The following is a description of a gene set: Human Gene Set: GOCC_CELL_SUBSTRATE_JUNCTION A cell junction that forms a connection between a cell and the extracellular matrix. species: Homo sapiens, and this is the list of marker genes: TRIM15, RPS19, ITGB1, RAB21, DMD, NHERF2, PPP1CB (NCBI Gene Id 5500), EFS, THSD1, PVR, IQGAP1, ITGB4, FLT1, RHOG, JAK1, CSPG4, NME2, PDLIM7, RPL7, HSPA8, TPM4, HACD3, CNN1, VIM, SENP1, EPHA2, KIF23, PPIA, LPXN, DND1, CAPN5, LASP1, SRCIN1, NPM1, FBLN7, TM4SF20, ITGA2, LRP1, ASAP3, IGF2R, DCTN4, RPS5, MDC1, AFAP1, RDX (radixin), PRUNE1 (prune exopolyphosphatase 1), PIP5K1C, COL17A1, TES, IRF2, PALLD, ATP6V0C, FBLIM1, YWHAG, DST, PTPN12 (protein tyrosine phosphatase non-receptor type 12), FERMT3, FHL2, HMCN1, TLN1, HMGA1, ADAM9, SVIL, UBOX5, PPFIA1 (NCBI Gene Id 8500), ACTB, RPL37A, RPL27, PRAG1, TNC, CDH13, CPNE3, CORO2B, GRB7, CSRP1, PTPRC, TLN2, FERMT1, GNB2, ARHGAP24, LIMD1, SLC4A2, RPL13A, PPFIBP1, MCAM, CNN2, TLE2, MSN, LIMS2, GAK, ITGB1BP1, NRAP, RPL7A, NPHS1, PEAK1, RSU1 (NCBI Gene Id 6251), RRAS, AIF1L, CORO1B, ARPC3, PAK1, SORBS2, G3BP1, ACTC1, RPL30, TWF1, PLAU, CD81, DAG1, RPL3 (ribosomal protein L3), CD44, ADGRB1, PTK2, GJA1, ITGA6, CAT, KRAS, PFN1, PCBP2, YES1, NECTIN2, GSN, TADA1, RPS10, ADAM10 (NCBI Gene Id 102), ACTG1, SMPX, IL1RL1, EZR, ITGB3, ACTN4, FHL1, S100A7, FLOT1 (flotillin 1), SLC6A4, ARPC5L, RPL23, CD46, MARCKS, FLNA, DLC1, RPS17, NUMB, PPP1R12A, RPS8, HSP90B1, HSPA1B, SPRY4, SDC4, PLEC, ENG, ARF1, FLNB, BSG, RPS16, PLAUR, CYBA, B2M, ITGA4, LMO7, RPL6 (NCBI Gene Id 6128), APBB1IP, ARHGEF2, PXN, AHNAK, PROCR, PDIA3, NHS, GNA12, CAP1, PGM5, VASP, CLASP1, ITGB8, GFRAL, AMBRA1, SCARF2, CLTC, FES, ITGB2, ADAM17 (NCBI Gene Id 6868), RRAS2, RHOU, PAK2, ARPC2, CNN3, ARPC5, LIMS1, LAYN, NCSTN, ARHGAP22, PI4KA, PDGFRB (platelet derived growth factor receptor beta), MPRIP, ZYX, HSPB1, ACTR2, SRC, PPIB, FLNC, PDLIM1, AKAP12, ITGB7, CASS4, DDR2, TSPAN9, RPL5, CDH2, ABCB4, MME, ITGA2B, ADD1, CAPN1, ADGRE5, DAB2, SYNE2, MAP2K1, MPZL1, LCP1, CTNNB1, JAK2, PARVB, CDC42, SH3KBP1, SORBS3, YWHAB, ITGB6, RAC2, SYNPO2, GIT1, RPS18, MRC2, FHL3, NEDD9, TEK, ACTR3, CHP1, TSPAN4, RPL18, MAPK1, FLII, CORO1C, ATP6V0A2, PTPRA, FGFR3, PARVG (parvin gamma), FLRT2, RPL12, EPB41L2, USP33, BCAR1, IL16, PTK7, MAPRE1, ARMC5, TNS2, RPS9, AJUBA, RPS15, NOX4, HSPA5, MAPRE2, ALOX15B, VCL, CBL, GNA13 (NCBI Gene Id 147219), FERMT2, JUP (NCBI Gene Id 3728), YWHAE, GIT2, PIK3R2, RHOA, ZFYVE21, SNTB2, LIMK1, KLF11, ARHGAP31, EPB41L5, FAT1, CTTN, FLOT2, RALA, LAMTOR3 (late endosomal/lysosomal adaptor, MAPK and MTOR activator 3), EHD3, SRP68, ANXA1, RPL38, ICAM1, FAM107A, CFL1, ANXA5, XIRP2, CALR, RPS13, L1CAM, TRPV4, SLC9A5, PDPK1, RPL10A, ITGB5, YWHAQ, DPP4, DOCK7, ITGA3, REXO2, XIRP1, PDCD6IP, NEXN, RAB10, RPLP0, RPS11 (ribosomal protein S11), DIXDC1, ARPC1B, RPL22, HYOU1 (hypoxia up-regulated 1, NCBI Gene Id 10525), HSPG2, PAK4, CAV2, FLRT1, TRIOBP, RPS3A, CIB2, TNS1, RPL4, BLOC1S6, ALCAM, FZD2, ARHGAP26, ACTN1, STX16, CYFIP1, LIMA1, RPL8, RPLP1, SCARB2, CAV3, ANXA6, EVL, SDCBP, NRP1, TGM2, NCKAP1, PEAK3, RPS4X, LAP3, ARHGEF7, RPS29, LMLN, ERBIN, SORBS1, EFNB2, ITGA5, RHOB, HSPA1A, PPP1CC, TNS4, SLC9A1, PTK2B, ITGA1, PIP5K1A, ZNF185, WASF1, CLASP2, ITGA11, RPS2, PACSIN2, RPS14, LPP, RPLP2, RND3, RAC1, FZD1, EGFR, THY1, P4HB, CD99, GDI2, MAP2K2, HCK, FAP, DNM2, MAPK3, ARF6, ARL14EP, MISP, EPPK1, TNS3, CD99L2, FLRT3 (fibronectin leucine rich transmembrane protein 3), TGFB1I1, CD9, MMP14, ITGBL1, RPL31, PARVA, CSRP2, PRKAR2A, PABPC1, CTNNA1, FOCAD, RPS3, HNRNPK, HSPA9, RPL9, SNAP23, YWHAZ, BCAR3, ENAH, CD59, CD151, STARD8, ACTN2, CAPN2, ALKBH6, RPS7, MAP4K4, RPL19, NFASC, CASK, SSH2, AVIL, ATAT1, SHROOM4, CAV1, CDC42EP1 (CDC42 effector protein 1), SNTB1, TNFSF13B, ILK, PHLDB2, SHC1 (NCBI Gene Id 6464), ITGA8, ITGAV, MYH9, ACTN3, LAMA3, TRIP6